Given this list of marker genes Ncbp1, Cmtr1, Tgs1, Rngtt, Ramac, Rnmt, Ncbp3, Cmtr2, here is a description of the gene set: Mouse Gene Set: GOBP_RNA_CAPPING studied in species Mus musculus The sequence of enzymatic reactions by which a cap structure is added to the 5' end of nascent RNA polymerase transcripts. Examples of RNA capping include 7-methyl-G caps found on all RNA polymerase II transcripts and nucleotide-containing cofactor caps, such as NAD(H) or FAD, found on bacterial trancripts.